The following is a description of a gene set: species: Homo sapiens As one of the most successful cancer therapeutic targets, estrogen receptor-alpha (ER/ESR1) has been extensively studied over the past few decades. Sequencing technological advances have enabled genome-wide analysis of ER action. However, comparison of individual studies is limited by different experimental designs, and few meta-analyses are available. Here, by ingesting large amount of E2-related transcriptomic data sets in breast cancer cell lines, we identified gene expression changes across 66 RNA-seq and 80 microarray experiments based upon the E2-induced fold change in gene expression. Among the 146 merged transcriptomic datasets, 27 different time points were annotated spanning from 5 minutes to 600 hours of estrogen stimulation. We separated all the comparisons into three signatures of duration: EstroGene_Early (≤6 hours, n = 58), EstroGene_Mid (6-24 hours, n = 44) and EstroGene_Late (≥ 24 hours, n = 44). Upregulated and downregulated genes present in the top 10th percentile of regulated genes in each individual study, and consistently present across at least 50% of studies at each time period, were extracted from each signature (early, mid, and late) and intersected accordingly. We identified 165, 59 and genes representing early, mid, and late estrogen response signatures, respectively. from publication Li Z, Li T, Yates ME, Wu Y, Ferber A, Chen L, Brown DD, Carroll JS, Sikora MJ, Tseng GC, Oesterreich S, Lee AV (PMID 37272757) Human Gene Set: LI_ESTROGENE_MID_E2_RESPONSE_UP High confident estrogen up-regulated genes in middle treatment duration (6-24 hours) in breast cancer cells merged from 44 NGS datasets-based comparisons (10% topmost up-regulated genes and consistent in at least 50% comparisons)., and this is the list of marker genes: CDC6, NOS1AP, MTHFD1L, RERG, AREG (amphiregulin), CDC45, TFF1, OLFM1, DTL, TPBG, C6orf141, DDIAS, ORC1, RBBP8